The following is a description of a gene set: Genes predicted to be targets of miRBase v22 microRNA hsa-miR-3973 in miRDB v6.0 with MirTarget v4 prediction scores > 80 (high confidence targets). Human Gene Set: MIR3973 from publication Chen Y, Wang X (PMID 31504780) species: Homo sapiens, and this is the list of marker genes: SMAD7, DIPK2A, ZNF706, ATP6V0D2, CELF3, ERLIN2, NECTIN2, PAK5, PPP5C, RNF149, TRDN, SCML2, BLOC1S6, ZNF281, C7orf25, PRPS2, MAGOHB, SERPINB2, THSD7A, FZD7, GPC6, AP1AR, RASA2, CENPW (centromere protein W), FGFR1OP2, KIAA1217, VAMP4, FBXL5, CCP110, ELL2, DCAF13, CXADR, VPS26A, IPMK, CWC22, KIAA1328, PDCD5 (programmed cell death 5), WWP1, ZCCHC2, CXCL12, PCDH9, USP37, ROBO2, MKX, AKAP11, PLCB1, RGPD6, IFRD1, PTPRE, WTAP, MINDY2, PRKRA, GNAI3, PRKCI, NVL, COX11, RORA, JAZF1, LRCH2, DCLK1, TENM1, RIMKLB, KLHL11, HIVEP2, KLF15, ANKRD20A4P, CRIPT, PLPP5, TAF12, KCTD18, NOX4, DLG5, FAM120A, NMD3, SPTSSA, PLAC8, AKIRIN1, VKORC1L1, CERS6, ZBTB41, ZFP91, VAV3, STT3B, ADAM22, C18orf54, SLC4A7, NET1, MEST, AZIN1, HEY2, TSHZ3, PIKFYVE, NBR1, TOMM20L, KAT6A, ATF7IP, DPH6, PMS1, AK7, NHSL1, NUS1, TMEM167A, TNFAIP8, NUFIP2, PBK, SCAI, LHX2, EPSTI1, ANKRD20A2P, DTNA, ATRX, ASXL2, TAB3, IKZF5, SNW1, RNF144B, ACTR3, PARD6G, TBC1D23, CLCA2, AHCTF1, AAK1, KMT2C, BAZ2B, RGPD5, GABRA4, LHX8, ADCY2, GABPA, COL5A2, SON, PDCL, KLHL2, THRAP3, NHLRC3, GK, HNRNPM, ACTR6, ADAMTSL3 (ADAMTS like 3), GFI1, SPTY2D1, NBEA, UBA5, SLC38A2, ZFP36L2, LARS1, LUC7L3, LCOR, ZNF451, GTDC1, MSH2, NBPF11, HIPK3, HBEGF, GPM6A, SORCS1, KLHL29, LRP2, INO80D, TMEM229A, CLOCK, NAA16, BAG5, S100PBP, GALNT1, FXR1, JMY, ADK, UGT2B7, PGR, RAB39A (RAB39A, member RAS oncogene family), MYZAP, PRKAA1, CSGALNACT2, EXD2, APBB2, ARRDC4, TAFA1, PDS5A, KLHL23, NUP50, ANKRD20A1 (ankyrin repeat domain 20 family member A1), GCC2, CACNA2D3, GFPT1, SUB1, SHROOM3, DCK (NCBI Gene Id 1633), MTMR6, SCN8A, PALLD, TCF7L2, CLCN4, CSNK1E, RAB8B, SOX14, RALGPS1 (Ral GEF with PH domain and SH3 binding motif 1), CFAP97, METTL8, FIGN, BOD1L1, SMURF2, POMC, UXS1, FGF23, PCDH19, CYP7B1, LAMP2, TPTEP2-CSNK1E, DDX46, ARL17A, CDKL2, CREBRF, UBE2D2, GLRB, CPSF6, KLHL28, PRPF4, TNKS, NPY1R, RGPD8, PLEKHA1, TMEM65, CACNB4, NEXMIF, KIAA1191, FAM13C, TCAF1, RICTOR, PHF13, OGFRL1, LARP4, MED13L (NCBI Gene Id 23389), FLRT3, ZNF770, RAB21, DCAF7, XRCC4, CDK17, RSPRY1, RRAGD, NOVA1, VPS29, MAPK8, BNIP2, SENP7, SESTD1, SELENOT, PSMA1, PSME3, ATXN2, AHI1, ST8SIA4, SMAD1, OGA, RAP2C, ZNF670, FSD1L, BBS10, CSPG5, SLC30A7, SBF2